Given this list of marker genes Mrps27, Kansl3, Mettl8, Mettl4, Fastkd2, C1qbp, Lrpprc, Fastkd3, Thap11, Mpv17l2, Shmt2, Cdk5rap1, Trub2, Mtg2, Nsun3, Kansl1, Coa3, Trmt10c, Mtg1, Prkaa1, Rpusd3, Alkbh1, Mtres1, Rcc1l, Ngrn, Rpusd4, Tefm, Rbfox2 (RNA binding protein, fox-1 homolog (C. elegans) 2), Kat8, Sirt3, Nsun4, Rmnd1, Taco1, Tsfm, Uqcc2, Malsu1, here is a description of the gene set: Mouse Gene Set: GOBP_REGULATION_OF_MITOCHONDRIAL_GENE_EXPRESSION species: Mus musculus Any process that modulates the frequency, rate or extent of mitochondrial gene expression. Gene expression is the process in which a gene's coding sequence is converted into a mature gene product (protein or RNA).